Given this list of marker genes AIRIM, SCN2B, MATK, C8orf33, QSOX2, CHTOP, MPHOSPH6, SPNS1, RWDD4, SLC25A38, SLC35E2A, PLA2G12A, GYG1, CCND2, COX18, JKAMP, XKRX, PES1, RASSF9 (NCBI Gene Id 9182), TMEM64, SLC25A39, CST7, EEF1A1, SPATA2L, KDM1B, SFXN3, CMAS, BLVRA, TRDMT1, SESN1, TRAPPC5, MTIF3, NSMCE3, ABCG2, PSEN2, NOL12, RRS1, CRK, TESC, LAMTOR4, RNASEH2A, RNF5, PRDX6, SAR1A, DAPK1 (death associated protein kinase 1), FERMT3, POLR3F, CYTH4, TOMM40, F8A1, PIP4K2B, MYL12B, MINDY3, THUMPD1, KTI12, PEX5, EPHX1, DHRS1, MBD2, TEX30, GABARAPL1, CLEC10A, EMP3, EFHD2, CYTH1, LDHB (NCBI Gene Id 3945), PPP3R1, SLC25A4, SNORD58B, TCN2, PRR29, S100A6, RARS2, SMIM5, DDX54, MAPKAPK3, NCK1, ITGAE, EXOSC5, IL10RA, ZCCHC9, DIPK1A, ISYNA1 (inositol-3-phosphate synthase 1), SNORA41, GPD1L, ACADM, GGA2, PMVK (NCBI Gene Id 10654), SELENOI, HPCAL1, CTPS2, EPHX4, HADH, VRK1, TMEM147, LSM14B, TARS1, GOLT1B, NIM1K, PEX13, FBXL3, SAP30L (NCBI Gene Id 79685), DNASE1L1, HOXC5, TSFM, MIF, TSR3, LYPLA2, BCDIN3D, PANX1, RNF11, SEMA7A, SLC25A12, AZIN1 (NCBI Gene Id 51582), CDK5, PITHD1, CRYZL1, TMC6, VIM, C11orf54, PNMA8B, KLF10, ENDOU, BNIP3, TMEM42, NGRN, SUCLG1, AP3S1, MEPCE, ADK, TREML2, ZFAND1, PLAAT3, PEX11B, BBS4, TMEM14C, PIK3IP1, PSMB2, C2orf42, NUFIP1, NFKBIA, SLC35A4, BLOC1S3, ESF1, FBXL12, TBXA2R, MTSS1, FAAP20, SEC11C, CDC40, SHISA5, NIPSNAP1, MRPL3, DHRSX, TPRKB, MPV17L2, SMPDL3A, ARL14EP, NUDT16, PCMTD1, MTM1, B3GNT8, ISCU, HCLS1, PIGP, RELT, C6orf118, RWDD1, SPTLC1, CNDP2, SMIM12, OXSM, DRAM2, GSTO1, NHLRC3 (NHL repeat containing 3), ASAH1, SRGN (NCBI Gene Id 5552), TM2D1, LTV1, CHMP7, LYRM2, PDE4D, here is a description of the gene set: CD4+ T helper lymphocytes that express interleukin-17 (Th17 cells) have critical roles in mouse models of autoimmunity, and there is mounting evidence that they also influence inflammatory processes in humans. Genome-wide association studies in humans have linked genes involved in Th17 cell differentiation and function with susceptibility to Crohn’s disease, rheumatoid arthritis, and psoriasis1-3. Thus, the pathway towards differentiation of Th17 cells and, perhaps, of related innate lymphoid cells with similar effector functions4, 5, is an attractive target for therapeutic applications. Mouse and human Th17 cells are distinguished by expression of the retinoic acid receptor-related orphan nuclear receptor RORγt, which is required for induction of IL-17 transcription and for the manifestation of Th17-dependent autoimmune disease in mice6. By performing a chemical screen with an insect cell-based reporter system, we identified the cardiac glycoside digoxin as a specific inhibitor of RORγt transcriptional activity. Digoxin inhibited murine Th17 cell differentiation without affecting differentiation of other T cell lineages and was effective in delaying the onset and reducing the severity of autoimmune disease in mice. At high concentrations, digoxin is toxic for human cells, but non-toxic synthetic derivatives, 20,22-dihydrodigoxin-21,23-diol (Dig(dhd)) and digoxin-21-salicylidene (Dig(sal)), specifically inhibited induction of IL-17 in human CD4+ T cells. Using these small molecule compounds, we demonstrated that RORγt is imporant for the maintenance of IL-17 expression in mouse and human effector T cells. These data suggest that derivatives of digoxin can be used as chemical probes for development of RORγt-targeted therapeutic agents that attenuate inflammatory lymphocyte function and autoimmune disease. Human Gene Set: GSE27241_WT_CTRL_VS_DIGOXIN_TREATED_RORGT_KO_CD4_TCELL_IN_TH17_POLARIZING_CONDITIONS_DN Genes down-regulated in polarizing CD4 Th17 cells: wildtype vs RORC knockout treated with digoxin. species: Homo sapiens from publication Huh JR, Leung MW, Huang P, Ryan DA, Krout MR, Malapaka RR, Chow J, Manel N, Ciofani M, Kim SV, Cuesta A, Santori FR, Lafaille JJ, Xu HE, Gin DY, Rastinejad F, Littman DR (PMID 21441909)